The following is a description of a gene set: Mouse Gene Set: GOBP_CENTRAL_NERVOUS_SYSTEM_NEURON_DEVELOPMENT species: Mus musculus The process whose specific outcome is the progression of a neuron whose cell body is located in the central nervous system, from initial commitment of the cell to a neuronal fate, to the fully functional differentiated neuron., and this is the list of marker genes: Arx (NCBI Gene Id 11878), Nr2e1, B4galt5, Crkl, Agtpbp1, Tctn1, Dcc, Samd4b, Prkca, Fgf8, D130043K22Rik, Adarb1, Pafah1b1, Gli2, Slit2, Ptk2, Ogdh, Btg2, Lhx6, Npy, Pten, Wdr47, Dubr, Draxin, Grcc10, Sema3e, Szt2, Ephb3, Atp7a, Spg11, Ntf3, Rac3, Gba2, Lep, Cntn2, Disc1, Sptbn4, Gbx2, Nova2, Lingo1, Plxna4, Plxna3, Sox1, Dclk1, Rac1, Nanos1, Dcx, Uqcrq, Gnaq, Ephb2, Sema3a, Pals1, Plxna1, Lmx1b, Chrnb2, Arhgap35, Atg7, Prdm8, Nfib, Drd1, Nr4a2, Ttc36, Zeb2, Epha4, Lhx8, Rapgef2, Cdk5, Dclk2, Scn1b, Brinp1, B4galt6, Hprt1, Wnt5a, Kifbp, Sall3, Nin, Tfap2a, Nrp2, Gata2, Ephb1, Scyl2, Zmiz1, Tsku, Arhgef28, Taok1, Nhlh2, Robo2, Neurog2, Ndel1, Atf5, Gabrb1, Crk, Fgfr2, Nrp1, Secisbp2, Foxg1, Fbxo45, Ubb, L1cam, Robo1, Phox2b, Agbl4, Bhlhe22, Drd2 (NCBI Gene Id 13489), Ntrk2, Cdh11, Mycbp2, Fezf2, Slc4a10, Ascl1, Ndnf, Fgfr1